The following is a description of a gene set: Reactome Pathway: Interleukin-4 and Interleukin-13 signaling part of: Signaling by Interleukins studied in species Homo sapiens Interleukin-4 (IL4) is a principal regulatory cytokine during the immune response, crucially important in allergy and asthma. When resting T cells are antigen-activated and expand in response to Interleukin-2 (IL2), they can differentiate as Type 1 (Th1) or Type 2 (Th2) T helper cells. The outcome is influenced by IL4. Th2 cells secrete IL4, which both stimulates Th2 in an autocrine fashion and acts as a potent B cell growth factor to promote humoral immunity. <br><br>Interleukin-13 (IL13) is an immunoregulatory cytokine secreted predominantly by activated Th2 cells. It is a key mediator in the pathogenesis of allergic inflammation. IL13 shares many functional properties with IL4, stemming from the fact that they share a common receptor subunit. IL13 receptors are expressed on human B cells, basophils, eosinophils, mast cells, endothelial cells, fibroblasts, monocytes, macrophages, respiratory epithelial cells, and smooth muscle cells, but unlike IL4, not T cells. Thus IL13 does not appear to be important in the initial differentiation of CD4 T cells into Th2 cells, rather it is important in the effector phase of allergic inflammation. IL4 and IL13 induce “alternative activation” of macrophages, inducing an anti-inflammatory phenotype by signaling through IL4R alpha in a STAT6 dependent manner. This signaling plays an important role in the Th2 response, mediating anti-parasitic effects and aiding wound healing (Gordon & Martinez 2010, Loke et al. 2002) There are two types of IL4 receptor complex. Type I IL4R (IL4R1) is predominantly expressed on the surface of hematopoietic cells and consists of IL4R and IL2RG, the common gamma chain. Type II IL4R (IL4R2) is predominantly expressed on the surface of nonhematopoietic cells, it consists of IL4R and IL13RA1 and is also the type II receptor for IL13.. The second receptor for IL13 consists of IL4R and Interleukin-13 receptor alpha 2 (IL13RA2), sometimes called Interleukin-13 binding protein (IL13BP). It has a high affinity receptor for IL13 (Kd = 250 pmol/L) but is not sufficient to render cells responsive to IL13, even in the presence of IL4R. It is reported to exist in soluble form and when overexpressed reduces JAK-STAT signaling. It's function may be to prevent IL13 signalling via the functional IL4R:IL13RA1 receptor. IL13RA2 is overexpressed and enhances cell invasion in some human cancers (Joshi & Puri 2012).<br><br>The first step in the formation of IL4R1 (IL4:IL4R:IL2RB) is the binding of IL4 with IL4R. This is also the first step in formation of IL4R2 (IL4:IL4R:IL13RA1). After the initial binding of IL4 and IL4R, IL2RB binds, to form IL4R1. Alternatively, IL13RA1 binds, forming IL4R2. In contrast, the type II IL13 complex (IL13R2) forms with IL13 first binding to IL13RA1 followed by recruitment of IL4R.<br><br>Crystal structures of the IL4:IL4R:IL2RG, IL4:IL4R:IL13RA1 and IL13:IL4R:IL13RA1 complexes have been determined. Consistent with these structures, in monocytes IL4R is tyrosine phosphorylated in response to both IL4 and IL13 while IL13RA1 phosphorylation is induced only by IL13 and IL2RG phosphorylation is induced only by IL4.<br><br>Both IL4 receptor complexes signal through Jak/STAT cascades. IL4R is constitutively-associated with JAK2 and associates with JAK1 following binding of IL4 or IL13. IL2RG constitutively associates with JAK3. IL13RA1 constitutively associates with TYK2. <br><br>IL4 binding to IL4R1 leads to phosphorylation of JAK1 (but not JAK2) and STAT6 activation. <br><br>IL13 binding increases activating tyrosine-99 phosphorylation of IL13RA1 but not that of IL2RG. IL4 binding to IL2RG leads to its tyrosine phosphorylation. IL13 binding to IL4R2 leads to TYK2 and JAK2 (but not JAK1) phosphorylation (Roy & Cathcart 1998, Roy et al. 2002).<br><br>Phosphorylated TYK2 binds and phosphorylates STAT6 and possibly STAT1. <br><br>A second mechanism of signal transduction activated by IL4 and IL13 leads to the insulin receptor substrate (IRS) family. IL4R1 associates with insulin receptor substrate 2 and activates the PI3K/Akt and Ras/MEK/Erk pathways involved in cell proliferation, survival and translational control. IL4R2 does not associate with insulin receptor substrate 2 and consequently the PI3K/Akt and Ras/MEK/Erk pathways are not activated (Busch-Dienstfertig & González-Rodríguez 2013)., and this is the list of marker genes: IL13, TNFRSF1B, IL23A, POU2F1, STAT1, OPRD1, PTGS2, SOCS3, MMP9, ITGB2, RORC, IL4, MYC, IL2RG, TWIST1, HGF, IL1A, ANXA1, MCL1, LAMA5, GATA3, JAK1, CD36, TP53, IRF4, MMP3, MMP1, CXCL8, SOCS5, CCL22, RHOU, CCL11, F13A1, IL4R, CCND1, LCN2, TIMP1, NANOG, CCL2, FOXO3, ITGAM, IL1B, IL12B, IL23R, SOX2, OPRM1, JAK3, MAOA, POMC, MMP2, ALOX5, BCL6, IGHE, HSPA8, SAA1, MUC1, HIF1A, BATF, TYK2, VEGFA, IL6, FN1, VIM, ITGB1, COL1A2, IGHG1, FCER2, HSP90AA1, IL12A, IGHG4, IL13RA1, NOS2, TNF, BIRC5, ZEB1, ITGAX, FASLG, AKT1, JAK2, PIK3R1, VCAM1, IL18, IL13RA2, BCL2L1, ALOX15, ICAM1, STAT3 (signal transducer and activator of transcription 3), FSCN1, S1PR1, FOXO1, FGF2, BCL2, SOCS1, OSM, CDKN1A, LBP, CEBPD, JUNB, IL17A, RORA, IL10, HMOX1, NDN (NCBI Gene Id 4692), IL6R, TGFB1, PIM1, STAT6, LIF, IL17F, HSP90B1, FOS